The following is a description of a gene set: Genes down-regulated in comparison of effective memory CD4 T cells versus NK cells. studied in species Homo sapiens In the present study we used Affymetrix oligonucleotide microarrays to produce gene transcription profiles for the major leukocyte types in humans. This comprehensive dataset enabled us to not only establish which genes were expressed in each leukocyte type, but also which genes were expressed in each subset after activation. The used of a comprehensive dataset of gene profiles from all the major human leukocyte subsets enabled a novel and powerful means for identification of genes associated with single leukocyte subsets, or different immune paradigms. from publication Jeffrey KL, Brummer T, Rolph MS, Liu SM, Callejas NA, Grumont RJ, Gillieron C, Mackay F, Grey S, Camps M, Rommel C, Gerondakis SD, Mackay CR (PMID 16474395) Human Gene Set: GSE3982_EFF_MEMORY_CD4_TCELL_VS_NKCELL_DN, and this is the list of marker genes: LYL1, TYK2, TCEA2, GH2, RPS27L, SGPP1, S100B, HMOX1, DCAF11, TNS3, LRRC41, PIGO, FRMD4A, RAB27B, MEGF9, SLC39A2 (solute carrier family 39 member 2), MNAT1, CR2, FRAT2, SEMA6A, RFTN1, FBXO41, EPHX1, FCGR3B, CRP, PDK3, PDE6G, SIGLEC5, MEA1, SECTM1, NCR3 (NCBI Gene Id 91958), USP22, PTK2B, PLCG2, CERS6, DCC, TRIM32, SOCS3, TYROBP, TRIO, TENM1, GSC2, CFD, CDIP1, IFI30, CCR1 (C-C motif chemokine receptor 1), DMAC2, RHBDF2, CTSW, VPS26C, SOHLH2, AOAH, BCAS1, BLCAP, ADM, SIGLEC9, NFKBIL1, NES, FGL2, TST, UBIAD1, UBAC1, TPI1, PMP2, ANXA2P1, RSAD1, JAKMIP2, HCK, LAPTM4B, LAT2, HK3, PPIP5K1, CHRNA2, TMEM94, SYK, TULP4, JUN, NLRX1, YPEL1, TBL1X, IRF7, RUNX1T1, TBL3, EPB41L3, TUB, CEBPD, KIAA0930, MTTP, MRPL33, CD302, RPRD2, ZBTB10, IRS1, CD160, ARRB1, PECAM1, CLEC1A, LILRA1, IFNAR1, KIR3DL3, ASTN1, CYRIA, ARAP1, ATG101, RBP1, CBS, RAB7A, TUBG1, ZNF200, SUOX, RGS3, BAALC-AS1, LMO2, FEN1, C5AR1 (complement C5a receptor 1), ZNF442, PLEKHF1, FAM193A, CTSF, NFIC (nuclear factor I C), GRIN2D, CD38, GCA, MAPKAPK3, NELL1, ELMO1, USB1, NAT8, CCNJL, IMPACT, YIPF3, TBC1D10B, PIK3CG, H1-0, MYO1E, GAS2L1, PRDM13, FDPS, RNASE3, MRPL13, DAGLA, ELMO2, NUMA1, REXO4, TXK, ADAMTS5 (ADAM metallopeptidase with thrombospondin type 1 motif 5), TSPOAP1, UCKL1, VIPAS39, CD180, IRF9, ZNF410, RGS19, RGS9, VNN2, SLC10A1, CAT, SPART, ODAD2, MAGEA5P, KLRF1, UTP11, SLC17A9, TPD52L1, KIFAP3, SCN2A, LYN, CHTOP, NUDT11, BSCL2, CD300A, GNLY, U2AF2, XBP1, NDUFC2, AFDN-DT, ASCC1, NCAM1, SERPINA1, BCAS4 (breast carcinoma amplified sequence 4), LUZP4, PISD, ITCH, MYH11, PCDHB3, MARCKSL1, RTP4, ZNF106, COQ2, MAB21L2, MYO1A, MICALL1, CEBPA, MKRN1, WASF2, MRPL15, TEX261, FBXO2